The following is a description of a gene set: Human Gene Set: HP_INCREASED_TOTAL_EOSINOPHIL_COUNT species: Homo sapiens Increased count of eosinophils in the blood. Increased total eosinophil count, and this is the list of marker genes: CLPB, ZNF341, CD247, DOCK8, IRF8, STAT3, CARD11, TCIRG1, TET2, FASLG, IL7R, CAPN3, CDSN, SRSF2, CD3D, IL6ST, NLRP1, ELANE, PDGFRA, SRP19, RNU4ATAC, ADA, DCLRE1C, CASP10, IPO8, POLD3, TBX21, RAG1, KIT, RAG2, CD3E, HLA-DRB1, RMRP, ZAP70, TRAC, RBM8A (NCBI Gene Id 9939), IKBKG, FOXP3, ASXL1, SREBF1, STAT6, NLRP3, PIK3CG, WAS, CHD7, SLC46A1, CARD9, PGM3, EXTL3, SPINK5, BCL11B, JAK1, LIG4, PSMB10, IL2RG, FAS, BTNL2, SLC27A4, GFI1